Given this list of marker genes Nup214, Kpna7, Kpna4, Pom121l2, Lbr (lamin B receptor), Ranbp6, Kpna2rt, Kpna1, Nolc1, Nup58, Kpna3, Tnpo1, Kpnb1, Ipo5, Kpna2, Brap, Pom121, Cabp1, Nfkbia, Nup98, Tnpo2, Kpna6, Nup153, Ipo4, here is a description of the gene set: species: Mus musculus Mouse Gene Set: GOMF_NUCLEAR_LOCALIZATION_SEQUENCE_BINDING Binding to a nuclear localization sequence, a specific peptide sequence that acts as a signal to localize the protein within the nucleus.